Given this list of marker genes Phex, Pdk2, Snw1, Lep, Usf1, Gas6, Snai2, Mlx, Trim24, Folr1, Rxrb, Fes, Srf, Csnk1a1, Pdia3, Col1a1, Mdm2, Prmt1, Brip1, Gprin3, Mn1, Scd4, Cyp24a1, Cdkn2b, Mat2a, Pim1, Mlxipl, Nfe2l2, Fgf23, Kank2, Med1, Tnc (NCBI Gene Id 21923), Folr2, Ogt, Postn, Cyp27b1, Bmt2, Vdr, Xbp1, Rps6kb1, Kdm6a, Pld1 (phospholipase D1), Mtor, Sfrp1, Kat2b, Penk, Ncoa1 (nuclear receptor coactivator 1), Usf2, Tnks, Gdap1, Rxra, Lpl, Sik2, Casr (calcium-sensing receptor), here is a description of the gene set: Mouse Gene Set: GOBP_CELLULAR_RESPONSE_TO_NUTRIENT Any process that results in a change in state or activity of a cell (in terms of movement, secretion, enzyme production, gene expression, etc.) as a result of a nutrient stimulus. species: Mus musculus